Given this list of marker genes NRXN1, RTN4R, OLFM1, NLGN1, CLU, MACO1, KCNA1, P2RY11, here is a description of the gene set: The process in which an activated neuronal cell receptor conveys information down a signaling pathway, resulting in a change in the function or state of a cell. This process may be intracellular or intercellular. species: Homo sapiens Human Gene Set: GOBP_NEURONAL_SIGNAL_TRANSDUCTION